Given this list of marker genes CYP2F1, EGR1, MAP2, ELOVL1, STK25, WDFY1, here is a description of the gene set: from publication Terao M, Kurosaki M, Barzago MM, Fratelli M, Bagnati R, Bastone A, Giudice C, Scanziani E, Mancuso A, Tiveron C, Garattini E (PMID 18981221) The mouse aldehyde oxidase AOH2 (aldehyde oxidase homolog 2) is a molybdoflavoenzyme. Harderian glands are the richest source of AOH2, although the protein is detectable also in sebaceous glands, epidermis, and other keratinized epithelia. The levels of AOH2 in the Harderian gland and skin are controlled by genetic background, being maximal in CD1 and C57BL/6 and minimal in DBA/2, CBA, and 129/Sv strains. Testosterone is a negative regulator of AOH2 in Harderian glands. Purified AOH2 oxidizes retinaldehyde into retinoic acid, while it is devoid of pyridoxal-oxidizing activity. Aoh2(-/-) mice, the first aldehyde oxidase knockout animals ever generated, are viable and fertile. The data obtained for this knockout model indicate a significant role of AOH2 in the local synthesis and biodisposition of endogenous retinoids in the Harderian gland and skin. The Harderian gland's transcriptome of knockout mice demonstrates overall downregulation of direct retinoid-dependent genes as well as perturbations in pathways controlling lipid homeostasis and cellular secretion, particularly in sexually immature animals. The skin of knockout mice is characterized by thickening of the epidermis in basal conditions and after UV light exposure. This has correlates in the corresponding transcriptome, which shows enrichment and overall upregulation of genes involved in hypertrophic responses. species: Mus musculus Genes down-regulated in Harderian gland tissue upon knockout of AOX4. Human Gene Set: TERAO_AOX4_TARGETS_HG_DN